The following is a description of a gene set: Human Gene Set: HP_REDUCED_FORCED_VITAL_CAPACITY species: Homo sapiens An abnormal reduction in the amount of air a person can expel following maximal inspiration. Reduced forced vital capacity, and this is the list of marker genes: MUC5B, TGFB1, MEGF10, ABCA3 (NCBI Gene Id 21), FCGR2A, TERC, LRP12, ADSS1, SFTPA1, SFTPC, RTEL1, STK36, SFTPA2, JAG2, HES7, CSF2RA (colony stimulating factor 2 receptor subunit alpha), ATP11A, TPM3, SLC25A21, TNNT1, GGPS1 (geranylgeranyl diphosphate synthase 1), STN1, SYT2, TERT, COL6A2, TNNC2, UNC45B, CFTR, TRIP4, POGLUT1, FAM13A, BAG3, MCIDAS, FKRP, PARN, DPP9, CRPPA (NCBI Gene Id 730683), NEK10, DSP